The following is a description of a gene set: studied in species Mus musculus A defense response against viruses mediated through an innate immune response. An innate immune response is mediated by germline encoded components that directly recognize components of potential pathogens. Mouse Gene Set: GOBP_ANTIVIRAL_INNATE_IMMUNE_RESPONSE, and this is the list of marker genes: Smarca5 (SWI/SNF related, matrix associated, actin dependent regulator of chromatin, subfamily a, member 5), Serinc3, Atad3a, Akap1, Nmbr, Rnf135 (NCBI Gene Id 71956), Oas1b, Dus2, Cxcl10, Uap1, Trim25, Oas1c, Ube2n, Dhx15, Nmb, Mavs, Clpb, Nlrp1a, Eif2ak2, Nlrp6, Traf3ip3, Usp44 (NCBI Gene Id 327799), Rpsa, Ifit3, Phb1, Marchf2, Ube2w (NCBI Gene Id 66799), Oas2, Ifit3b, Oas1e, Hcfc2, Sting1, Oasl2, Oas1g, Tnf, Morc3, Oasl1, Oas1d, Trim65, Ifit2, Oas1f, Dhx16, Zdhhc1, Nlrp1b, Mbl2, Zbp1, Nck1, Phb2, Pde12, Senp7, Oas1h, Usp20, Trim31, Serinc5, Trim6, Trim7, Tbk1, Oas3, Oas1a, Usp18, Dhx58, Ifih1, Rela, Traf6, Prkra, Rigi, Tmem120a, Irf3, Zdhhc11